Given this list of marker genes MLEC, PRDX5, PON2, C8orf33, ATP8A1, CAMK2N1 (calcium/calmodulin dependent protein kinase II inhibitor 1), REX1BD, CXCL1, CD37, CYTH3, ACP5, TNIK, SMG6, SREBF2, TMEM273, ABCB1, ZFP69, TM6SF1, MMD, SESN3, KIAA0586, CD86, DNMT3A, NR1I2, CTSW, ITIH5 (inter-alpha-trypsin inhibitor heavy chain 5), SORL1, GIMAP7, NIPAL1, DCAF8, CYP1B1 (cytochrome P450 family 1 subfamily B member 1), TRIM34, PRKCH, ZBTB20, CLEC10A, CAMK4, TRRAP, FAM20A, FNTA, TPGS2, ERMP1, JAZF1, USP3, RALGPS2, GFI1, ARAP2, UQCC2, STX16, SIK2, SEMA4F, EXT1, SMPDL3A, EPSTI1, F2R, ARSB, CTSB, IFIH1, NUDT6, NPC2, DKK3, DIPK1A, TGM2, CELF2, SUSD3, PLAC8, SAMD9L, POMGNT1, HECTD4, LY6E, SETD1B, SH3GL3, TBC1D2B, ICAM2, TRPS1, NTN4, IGHM, MIEN1, GPR68, LPIN2, PTPRE, CSGALNACT1 (chondroitin sulfate N-acetylgalactosaminyltransferase 1), FOS, DOT1L, NEFH (neurofilament heavy chain), IL10RB, DBNL, NRBP1, REEP4, MAGED2, CRTC3, RNF135, ADGB, IFT172, TMEM229B, MAP7, PUS7L, AREL1, CNKSR3, VCAM1, AK7, ARPC5, BANK1, PPP1R21, ASB2, KNSTRN, CDH1, SSBP2, KRT76, HLA-DMA, LZTFL1, SHROOM1, FEN1, MTMR3, MPV17, CHST11, HLA-DOB, ITGB2, WWP2, RNF10, CYP26B1, DNAJC6, SLC2A2, MEDAG, DLG3, CSTA, IDNK, FBXL6, STK38, AVPR1A, LPAR6 (NCBI Gene Id 10161), IL17D, SLA, ATP1A2, ENDOD1, XDH, SIRT5, CD96, DHRS3, CORO2A, PLIN2, EXTL3, RNF130, FASLG, DPP4, MS4A6A, PIGP, ZNF319, PNPLA7, SYCP2L, TNFSF10, AP1S2, CCR9, ASAP1, IPCEF1, TPPP, MCTP1, FIP1L1, NIPSNAP1 (NCBI Gene Id 8508), SERPINB6, SLC39A4, HGSNAT, TNFRSF25, NQO2, MCOLN3, MYRIP, EHD3, AGO1, TACC1, CYTH4, ITGA4, MICAL1, VWA5A, AR, SMURF1, DCAF4, WDR83OS, PPP2R5A, EEF1AKMT1, ATP6V1C2, NRP1, DDHD1, KCNK5, CCL28, BAZ2B, TXK, FILIP1L, ALDH7A1, KIAA0753, DOCK5, GIMAP4, MAPKAPK3, VAV3, NCF1, SMAD3, HIC1, TTC19, RGS12, HOXB4, PITPNC1, SIPA1L1, here is a description of the gene set: studied in species Homo sapiens Genes up-regulated in comparison of memory CD4 T cells treated with retinoic acid (tretinoin) versus untreated memory CD4 T cells. Human Gene Set: GSE13306_RA_VS_UNTREATED_MEM_CD4_TCELL_UP CD4(+)Foxp3(+) regulatory T (Treg) cells originate primarily from thymic differentiation, but conversion of mature T lymphocytes to Foxp3 positivity can be elicited by several means, including in vitro activation in the presence of TGF-beta. Retinoic acid (RA) increases TGF-beta-induced expression of Foxp3, through unknown molecular mechanisms. We showed here that, rather than enhancing TGF-beta signaling directly in naive CD4(+) T cells, RA negatively regulated an accompanying population of CD4(+) T cells with a CD44(hi) memory and effector phenotype. These memory cells actively inhibited the TGF-beta-induced conversion of naive CD4(+) T cells through the synthesis of a set of cytokines (IL-4, IL-21, IFN-gamma) whose expression was coordinately curtailed by RA. This indirect effect was evident in vivo and required the expression of the RA receptor alpha. Thus, cytokine-producing CD44(hi) cells actively restrain TGF-beta-mediated Foxp3 expression in naive T cells, and this balance can be shifted or fine-tuned by RA. from publication Hill JA, Hall JA, Sun CM, Cai Q, Ghyselinck N, Chambon P, Belkaid Y, Mathis D, Benoist C (PMID 19006694)